The following is a description of a gene set: Human Gene Set: REACTOME_ADIPOGENESIS studied in species Homo sapiens Adipogenesis, and this is the list of marker genes: MED10, LPL, PPARG, MED29, NCOR2, MED12, MED13, TBL1X, WNT10B, MED30, HNRNPU, FAM120B, KLF4, MED19, COX7A1, TBL1XR1, CDK8, CHD4, ADIRF, GATAD2B, MED6, ZNF423, MED15 (NCBI Gene Id 51586), NCOA1, HDAC1, CDK4 (NCBI Gene Id 92978), MED7, TGS1 (trimethylguanosine synthase 1), HDAC3, EP300, EBF2, MED26, MTA1, MTA3, PRDM16, HELZ2, EGR2, SMAD4, ZNF638, SLC2A4, NCOR1, CD36, NFKB1, MED9, SMAD1, TGFB1, GATAD2A, SREBF1, MED22, LEP, KLF5, BMP7, NCOA3, RELA, RBBP7, RBBP4, ZNF467, CHD9, MED14, MED8, HDAC2 (histone deacetylase 2), PLIN1, MED28, CREBBP, CHD3, CARM1, CDK19, SMARCD3, USP46, ANGPTL4, PPARA (peroxisome proliferator activated receptor alpha), MED1, MED11, CIDEA, MED24, MED13L, NR2F2, MED27, TNF, PCK1, MED31, MED18, NCOA6, PPARGC1A, DIO2, CEBPA, MED20, ADIPOQ, MED4, MED17, MED25, UCP1, ELOVL3, SREBF2, RXRA, EBF1, FABP4, WNT1, MED21, MED23, MTA2, NCOA2, MED16, PPARGC1B, CCNC, CCND3, CEBPD, CEBPB, THRAP3, MBD3